The following is a description of a gene set: Human Gene Set: HP_Y_LINKED_INHERITANCE species: Homo sapiens Y-linked inheritance A mode of inheritance that is observed for traits related to a gene encoded on the Y chromosome., and this is the list of marker genes: SRY, DAZ3, CDY2A, RPS4Y2, XKRY, TBL1Y, VCY, USP9Y, KDM5D, DDX3Y, DAZ1 (NCBI Gene Id 1617), RBMY1A1, DAZ2, HSFY1, CDY1, BPY2